Given this list of marker genes NBN, HRH2, NOLC1, BCL7B, SUB1, ZNF524, EBF1 (NCBI Gene Id 1879), EID1, C9orf40, IREB2, ENO3, SLC10A2, GSTZ1, FCGR2B (NCBI Gene Id 2213), ATP5F1A, PHPT1, RSL1D1, GNPNAT1, PRCC, PSMG1, MCM3AP, RPA1, REXO5, HNRNPA3, HSPE1, ZSCAN26, SOWAHC, MYC, CKMT1B, YME1L1, IGFBP1 (NCBI Gene Id 3484), TRIM37, CSTF2, UNCX, ABCG2, SEC31A, NUDT21, DIPK1B, SEH1L, NHP2 (NHP2 ribonucleoprotein), BIK (BCL2 interacting killer), MAN2C1, SMPD1, CHRM4, ISG20, SLC27A1, ZAP70, GUCD1, RPL36A, NSMCE1, NDUFAF1, SESN1, HTR3A, IL13RA2, UBAC1, PTPN9, IMPDH1, IFI35, ETHE1, NDUFA2, ANAPC1, LCK, HAUS3, SNRPG, RFC3, POLR1H, COX14, EHMT2 (euchromatic histone lysine methyltransferase 2), WDFY2, PRRX1, RPSA, ELF1, CCT3, ARHGDIA (Rho GDP dissociation inhibitor alpha), RPL12, ANAPC2, PON2, PBX2, RRAD, GBP2, HUS1, GADD45G, TCF21, STX1B, CAD, RAPSN, SMR3A, SNX3, MRPL23, MGLL, LYSMD1, PSMA1, SSBP2, SYPL1 (synaptophysin like 1), ATP2A3, COPE, ZHX1, TIAL1, TNPO1, TCIRG1, RPL18, PES1, GPAT4, GPC1, SSBP1, RBMS2, ACTL6B (NCBI Gene Id 51412), CCL7, AKR7A2, RPS25 (ribosomal protein S25), CCDC86, CDCA7L, PAM, GPLD1, SMPDL3A, CLP1, TBK1, WDR6, HELLS, SERTAD1, DEAF1, MRPL37, ZFP90, LTB, CHGA, NPC2, SMARCE1 (NCBI Gene Id 6605), PPRC1, VARS1, NDUFA12, SELENOH, RPL14, LATS2, ABT1, TTC39B, RPS8, TRMT2A, GGT5, PPT1, CLK2, CXCL14, DDX18, CDK5RAP3, IRF9 (interferon regulatory factor 9), PDE6D, ADAM23, UIMC1, SHMT1, S100A11, MRPS26, ZFX, SLC23A2, STC2, SIPA1, PSME1, POLRMT, ZNF639, FOXD3, HNRNPA1, FUT1, TBC1D24, COPS4, EBNA1BP2, MRPL40, MATN1, MTX1, TXNIP, PAN2, MIS18BP1, G3BP1, SERPINA12, POLA1, POPDC3, PPP5C, ANAPC5, RARS1, LBR, INMT, MGMT, TRPC6, HLA-DQA1, ZNF503, SLC19A1 (solute carrier family 19 member 1), RAP1A, DDX52, ACTL6A, KLKB1, AXL, KRT7, MAD2L1BP (NCBI Gene Id 9587), SUCLG2, EPRS1, SCAF11, SPRED2, DDX39B, MRAS, SDC2, COIL, AQR, here is a description of the gene set: Genes up-regulated in comparison of anergy induced CD4 T cells versus conventional CD4 T cells. studied in species Homo sapiens compare gene expression profiles between normal and anergic T cells and identify upregulated genes in anergic T cells Human Gene Set: GSE5960_TH1_VS_ANERGIC_TH1_UP from publication Zha Y, Marks R, Ho AW, Peterson AC, Janardhan S, Brown I, Praveen K, Stang S, Stone JC, Gajewski TF (PMID 17028589)